The following is a description of a gene set: species: Homo sapiens The process in which relatively unspecialized cells acquire specialized structural and/or functional features that characterize the cells of the spinal cord. Differentiation includes the processes involved in commitment of a cell to a specific fate. Human Gene Set: GOBP_CELL_DIFFERENTIATION_IN_SPINAL_CORD, and this is the list of marker genes: TBX20 (NCBI Gene Id 57057), ISL2, PTCH1, WNT3A, LONRF2, PHOX2A, CLN8, NOTCH1, GSX2, NKX2-2, ASCL1, GLI3, SCYL3, TAL1, SOX13, FOXN4, HOXC10, DMRT3, DYNC2H1 (NCBI Gene Id 79659), LBX1, MDGA1, OLIG2, SOX1, LMO4, TCTN1, PAX7, HOXD10 (homeobox D10), NFE2L1, GBX1, SCYL1, DBX1, DLL4, WNT1, LHX3, GLI2, OLIG3, LHX1, LHX4, ISL1, ZC4H2, GSX1, GIGYF2, MNX1, ABT1, LHX5, IFT172, GATA2, SHH, MDGA2, SUFU, SOX6, DRAXIN, GDF7